The following is a description of a gene set: Abnormal occipital bone morphology Human Gene Set: HP_ABNORMAL_OCCIPITAL_BONE_MORPHOLOGY species: Homo sapiens Abnormality of the occipital bone of the skull., and this is the list of marker genes: EHMT1, ATP7A, NEUROG1, CYP2R1, KIF11, ATP6V1B2, ASPM, GDF11, TOR1A, PEX12, MCTP2, LFNG, DPYSL5, UBE3A, ADSL, MED12, HK1, PIGN, CDKN1C, METTL23, SATB2, SH3PXD2B, TWIST1, SNRPN, RNU4ATAC, RPS23, PPP1R21, PLAGL1, ITCH, NRAS, PEX16, ERF, MYCN, RALGAPA1, MESP2, WASHC5, PEX13, CNOT3, DLL3, TMEM70, CYP27B1, NFIX, KATNB1 (NCBI Gene Id 10300), NDE1, TAF1, IL11RA, PEX26, CCDC22, IFT43, MAN1B1, PPIB, HYMAI, IFT122, RIPPLY2, SYNE1, DYRK1A, SLC25A12 (solute carrier family 25 member 12), PEX14, SLC34A3, PEX3, OCRL, DPM1, GJA8, KRAS, FLNA, GJA5, ZIC1, WDR35, MAN2B1, IGF2, KAT6B, AMER1, FIG4 (FIG4 phosphoinositide 5-phosphatase), KIF7, PEX6, CNOT1, WDR73, HRAS, UBE3B, PEX19, VPS35L, PEX10, HES7, TUBB3, MOGS, PEX2, CHUK, UFC1 (NCBI Gene Id 51506), OCA2, SMG9, SLC35A1, NOTCH2 (NCBI Gene Id 55574), EZH2, KCNQ1OT1, FGFR2, CTSK, PIGA, GLI3, ALX4, SOX6, PTCH1, PEX1, INPPL1, VDR, SETD1B, IFT81, WDR19, IFT52, TBX6, RELN, RTTN, RNU4-2, TFAP2B, KCNQ1, PEX5, VAC14, CDK13, PEX11B, FLNB, TBC1D24, OTUD6B